Given this list of marker genes CALR, CXCR3, GPSM3, ADAM10, S1PR1, ROBO3, FGF16, KLRC4-KLRK1 (NCBI Gene Id 100528032), KLRK1, NINJ1, FEZF2, ITGA2, MIR16-1, STX4, PADI2, NCKAP1L (NCK associated protein 1 like), RARRES2, PTN, ADGRA2, RYK, MIR149 (NCBI Gene Id 406941), CYP19A1, AGER, S100A7, HRG, MTUS1, GAS6, CSF1, APP, LBP, TMEM102, PERP (p53 apoptosis effector related to PMP22), MCU, HSPB1 (heat shock protein family B (small) member 1), STK39, MIR424, PLA2G7, PTK2, CCL2, CXCR4, BST1, USP14, LGALS9, DPP4, BMPR2, IL23A, FGF2, CCL7, PDGFB, MEGF8, CCL19, CXCL13, ZNF580, VEGFD, NTF3, C1QBP, MYCBP2, MAPK1, GREM1, MMP28, NBL1, ARTN, ELANE, THBS4, NTRK3, CXCL12, CCR1, CCN3, IL6, SLAMF8, IL6R, CREB3, NEDD9, F2RL1, DAPK2, LPAR1, CXCL10, TGFB1, DNM1L, FGF18, FGFR1 (fibroblast growth factor receptor 1), CORO1B, CCR6, FGF1, NRP1, STX3, PTPN2, POU4F2, PTPRO, P2RY12, TNFSF14, FPR2, VEGFA, SWAP70, CCL26, ATOH7, TUBB2B, LYN, PPM1F (NCBI Gene Id 9647), JAM3, CCL5, HMGB1, SEMA5A, F3, PTK2B, C5AR2, TNFSF18, SERPINE1, MICOS10-NBL1, SMAD3, SUCNR1, P2RX4, TRPV4, CCL21, CDH13, SPI1, TIRAP (NCBI Gene Id 115469), CCL4, GPR18, SCG2, CCL1, PTPRJ, THBS1, SLIT2, GPR183, IL12A, CD74, FGF10, CSF1R, ANO6, SLC8B1, MPP1, VEGFC, MAPK3, HDAC6, KDR, WNK1, NOVA2, FGF4, RIN3, VEGFB, DDT, MIF, WNT3, XCL1, TREM2, CYRIB, CMKLR1, SLIT1, RIPOR2, MDK, DEFB124, RAC1, TNFAIP6, C3AR1, IL34, C5, PGF, MET, STAP1 (signal transducing adaptor family member 1), AIF1, CCR7, PLXNA3, OXSR1, SLAMF1, CCR2, MIR223, EDN1, S100A14, PDGFRB, ADAM17, EDN3, DSCAM, PDGFD, MIR34A, PDGFRA, TPBG, ROBO1, ANGPT2, DEFB131A (defensin beta 131A), DUSP3 (NCBI Gene Id 284066), ROBO2, RAC2, SMOC2, CX3CR1 (C-X3-C motif chemokine receptor 1), SEMA3F, AKIRIN1, CXCL17 (C-X-C motif chemokine ligand 17), AZU1, F7, NOTCH1, MOSPD2, CASR, KIF21A, TBR1, WNT5A, CCL3, PLXNA4, CTTN, MSTN, GSTP1, CXCL8, C5AR1, PRKD1 (protein kinase D1), PRKD2 (protein kinase D2), LGMN, TMSB4X, YTHDF1, EFNB2, CAMK1D, EDN2, MIR15A, WNT3A, DUSP1, IL16, here is a description of the gene set: Any process that modulates the frequency, rate or extent of the directed movement of a motile cell or organism in response to a specific chemical concentration gradient. studied in species Homo sapiens Human Gene Set: GOBP_REGULATION_OF_CHEMOTAXIS